Given this list of marker genes DHRS9, SORD, ADH6, ADHFE1 (NCBI Gene Id 137872), ADH1A, DHRS7C, RDH16, DHRS3, ADH5 (alcohol dehydrogenase 5 (class III), chi polypeptide), ADH4, AKR1A1, RDH11, RDH10, RDH5, HSD17B6, RDH12, SDR16C5, AKR1C3, RDH8, SDR9C7, ADH1C, ADH1B, ADH7, HSD17B13, here is a description of the gene set: species: Homo sapiens Human Gene Set: GOMF_ALCOHOL_DEHYDROGENASE_NADPLUS_ACTIVITY Catalysis of the reaction: an alcohol + NAD+ = an aldehyde or ketone + NADH + H+.